The following is a description of a gene set: from publication He P, Lim K, Sun D, Pett JP, Jeng Q, Polanski K, Dong Z, Bolt L, Richardson L, Mamanova L, Dabrowska M, Wilbrey-Clark A, Madissoon E, Tuong ZK, Dann E, Suo C, Goh I, Yoshida M, Nikolić MZ, Janes SM, He X, Barker RA, Teichmann SA, Marioni JC, Meyer KB, Rawlins EL (PMID 36493756) Interm chondrocyte studied in species Homo sapiens Human Gene Set: HE_LIM_SUN_FETAL_LUNG_C0_INTERM_CHONDROCYTE, and this is the list of marker genes: SNAI1, COL9A1, SOX9, PLEKHG1, FOXP2, COL15A1, FRZB, COL11A2, AIF1L, SUSD5, RARG, TTYH1, DOK5, EPYC, THSD4, FGFR2, COL9A3, HHIP, DLK1, SLC2A1, COL9A2, EYA4 (NCBI Gene Id 56002), BOC, RFLNA, DEPTOR, TENM3, PRRX1, COL2A1, CRYL1, HAPLN1, CYP26B1, FIBIN, CNMD, SOX5, CDC42EP3, MPPED2, ACAN, NOTUM, PSAT1, WFDC2, MAG, PEG3, LINC00511, PYGL, MATN4, VSNL1, DHRS3, TYRP1, SCARB1, SEMA6A, COL11A1, S100B, WWP2, PRELP, CAPN6, CHST11, AMOT, MECOM (NCBI Gene Id 4197), BEX1, SOX6, YPEL2, PDGFC, FGFRL1, NEDD9, RGCC, CTHRC1, DAAM2, CRISPLD1